The following is a description of a gene set: Global genome NER. Pathway ID: N01425. Pathway type: Reference. Pathway class: nt06502 Nucleotide excision repair. Pathway Definition from KEGG: (CRL4+DDB2) == (XPC+RAD23A,RAD23B+CETN2) -> (XPC+CETN2) == (ERCC3+ERCC2) == (GTF2H) == (CAK) Human Gene Set: KEGG_MEDICUS_REFERENCE_GLOBAL_GENOME_NER studied in species Homo sapiens, and this is the list of marker genes: RBX1, ERCC2 (ERCC excision repair 2, TFIIH core complex helicase subunit), CETN2, CDK7, DDB1, GTF2H3, GTF2H5, RAD23B, RAD23A, XPC, CCNH, GTF2H1, CUL4A, GTF2H2, DDB2, ERCC3, MNAT1, GTF2H4